The following is a description of a gene set: species: Homo sapiens Any process that results in a change in state or activity of a cell or an organism (in terms of movement, secretion, enzyme production, gene expression, etc.) as a result of an alkaloid stimulus. Alkaloids are a large group of nitrogenous substances found in naturally in plants, many of which have extracts that are pharmacologically active. Human Gene Set: GOBP_RESPONSE_TO_ALKALOID, and this is the list of marker genes: CRHBP, TGM2, DNMT3A, RECQL5, CARTPT, SLC1A3, FOSB, DHX15, FADD, DRD5, RAD51, HTR1B, TMEM38B, UQCRC1, ADRA2A, HOMER1, CPT1A, RYR3, BLM, SLC6A3, SLC34A1, CDK5, CASP3, CASQ2, PRKCE, SDK1, BCHE, SLC1A2, SETD2, PRKAA1, PPP1R9B, CCNA2, ADORA2A, SOX17, SPIDR, CREB1, PRKCG, SNCA, OXT, RGS4, CACNA1S, RYR2, HTR2A, SELENON, CRH, CAD, OPRM1, MYC, ABCB1, PPP2R2A, DRD3, ST8SIA2, EFTUD2, CASP7, SMPD1, CASP6, COMT, HSP90AA1, SLC8A1, FKBP5, GRM2, MDM2, RYR1, CHRNB2, MYRF, EHMT2, TMEM38A, EN1, GRIA1, SLC1A1, HES1, GNAL, PPP5C, TRPA1, SLC6A4, PDX1, HDAC5, BCL2L1, GSTM2, TACR3, HDAC2, ABAT, PPP1R1B, PITX3, HOMER2, DRD1, ADCY8, OPRK1, DRD4, GPRIN3 (GPRIN family member 3), TRPV1, DRD2, CACNG4